The following is a description of a gene set: Catalysis of the cleavage of the C-O-P bond in the AP site created when DNA glycosylase removes a damaged base, involved in the DNA base excision repair pathway (BER). Mouse Gene Set: GOMF_DNA_APURINIC_OR_APYRIMIDINIC_SITE_ENDONUCLEASE_ACTIVITY studied in species Mus musculus, and this is the list of marker genes: Alkbh1, Neil2 (nei like 2 (E. coli)), Neil1, Ogg1, Polb, Hmces, Nthl1, Hmga2, Hmga1, Apex2, Rps3, Hmga1b, Neil3, Apex1, Aplf